The following is a description of a gene set: species: Mus musculus Mouse Gene Set: chr9E3, and this is the list of marker genes: 1700008A23Rik, Gm26423, 4933431K14Rik, Clstn2, Gm18291, D030062O11Rik, Gm28934, Ctsh, 4921534H16Rik, Cldn18, Gm23949, Gm2324, 9430037G07Rik, Dipk2a, Gm2950 (predicted gene 2950), Gm15493, Gm5619, Tmem41b-ps, A930006L05Rik, Gm22866, Gm25417, Trpc1, Prss35, Zbtb38, Gm2497, Gm23176, Gm5920, Slc9a9, Gm8495, Prr23a4, Mir6386, Gm5066, Adamts7, Zic4, Gm29240, Zic1, Gm18766, Zfp949, Prr23a3, Paqr9, Pgm3, 4930422M22Rik, Slc25a36, Gm32281, Trim43a, Copb2 (COPI coat complex subunit beta 2), Ripply2, Gm28703, Nt5e, Gm28167, 1700065D16Rik, Gm10163, Trim43c, Gm5368, Foxl2os, Bcl2a1b, Dzip1l, Mthfs, Minar1, Trim43b, Stag1, Gm18016, Morf4l1 (mortality factor 4 like 1), Rwdd2a, Mrap2, Gm28231, Gm1123, Gm23707, Gk5, Rpl7a-ps10, Gm26082, Nmnat3, 4930524O08Rik, Il20rb, Chst2, Faiml (Fas apoptotic inhibitory molecule like, NCBI Gene Id 623459), Gm31409, Gm2396, Sox14, A330041J22Rik, Gm24004, Gm28530, Gm22717, Mir7656, Gm28877, Gm5371, Gm24200, 4930540E01Rik, Gm25125, Gm16185, Gm29478, Armc8, Rbp2, Mrps22, 9330159M07Rik, B430319G15Rik, Me1, Gm9541, 9430062P05Rik, Gm28729, Prr23a1, Gm25582, Mras (muscle and microspikes RAS), Gm47403, Cep70, U2surp, Gm8449, Atr, Gm28166, Gm5370, A730094K22Rik, Foxl2, Gm16126, Rasgrf1, 4930579C12Rik, Gm33778, Gm26611, Pik3cb, Gm9621, Gm37249, Plscr1, Gm10634, 9330154J02Rik, Snhg5, Syncrip, Gm29241, Gm18378, Tfdp2, Snx14, Plscr1l1, Dbr1, Prr23a2, Slc35g2, 2610303G11Rik, Ibtk, Tpbg, Dop1a, Bcl2a1a, Gm33700, Gm10123, Gm16794, Gm16200, Gm24178, Gm36539, BC043934, Esyt3, 4930519F24Rik, E330023G01Rik, Gm30849, 1700034K08Rik, Gm16202, Gm19325, Nme9, Gm3081, Tent5a, Gm8524, Gm22985, Ube3d, Gm5369, Atp1b3, Gm29396, Tmed3, Spsb4, Nck1, Gm19498, Gm29605, C430002N11Rik, Gm8228, Faim, Snap91, 4933400C23Rik, 4930554C24Rik, Gm25607, Xrn1, Plod2, Gm5620, Gm28266, Rbp1, Gm19280, Gm8661, Gm19193, Gm9540, Gm8641, Mir184 (NCBI Gene Id 387179), Gm18914, 1700017I07Rik, Pisrt1, Itpa-ps2, Gm17944, Gm26126, Gm8282, Gm26101, Ankrd34c, Cep162, Plscr2 (phospholipid scramblase 2), Tbc1d2b, Gm9775, Cyb5r4, Gm22830, Gm20561, Gm23594, Gm2495, Gm34397 (predicted gene, 34397), A030012G06Rik, 4930579K19Rik, Pxylp1, Plscr4, Gm39404, Rasa2, Gm29603, Rnf7, A4gnt, Tbx18 (NCBI Gene Id 76365), Bcl2a1d, Pcolce2, Plscr5 (NCBI Gene Id 331000), Mthfsl, Trim42, Gm8520, Pls1, Gm16010, Gm22138